The following is a description of a gene set: Genes down-regulated in Ly6C high monocytes: untreated versus rosiglitazone. species: Homo sapiens from publication Gautier EL, Chow A, Spanbroek R, Marcelin G, Greter M, Jakubzick C, Bogunovic M, Leboeuf M, van Rooijen N, Habenicht AJ, Merad M, Randolph GJ (PMID 22855714) Human Gene Set: GSE32034_UNTREATED_VS_ROSIGLIZATONE_TREATED_LY6C_HIGH_MONOCYTE_DN PPARγ is known for its anti-inflammatory actions in macrophages. However, which macrophage populations express PPARγ in vivo and how it regulates tissue homeostasis in the steady state and during inflammation is not completely understood. We show that lung and spleen macrophages constitutively expressed PPARγ, while other macrophage populations did not. Recruitment of monocytes to sites of inflammation was associated with induction of PPARγ as they differentiated to macrophages. Its absence in these macrophages led to failed resolution of inflammation, characterized by persistent, low-level recruitment of leukocytes. Conversely, PPARγ agonists supported an earlier cessation in leukocyte recruitment during resolution of acute inflammation and likewise suppressed monocyte recruitment to chronically inflamed atherosclerotic vessels. In the steady state, PPARγ deficiency in macrophages had no obvious impact in the spleen but profoundly altered cellular lipid homeostasis in lung macrophages. Reminiscent of pulmonary alveolar proteinosis, LysM-Cre x PPARγflox/flox mice displayed mild leukocytic inflammation in the steady-state lung and succumbed faster to mortality upon infection with S. pneumoniae. Surprisingly, this mortality was not due to overly exuberant inflammation, but instead to impaired bacterial clearance. Thus, in addition to its anti-inflammatory role in promoting resolution of inflammation, PPARγ sustains functionality in lung macrophages and thereby has a pivotal role in supporting pulmonary host defense., and this is the list of marker genes: MZT2B, C1QBP, CLCNKB, RAMAC, GPX7, FLCN, CFDP1, RBM3, SPR, GPAT4, RPS23, ST8SIA3, CAVIN2, CCR5, TAF8, NDUFC2, RBM8A, ZNF354A, MCM3AP, CA4, PRPSAP2, YPEL3, NDFIP1, APIP, MRPS12, BLTP3A, CASP9, ENTPD7, CCNI, SEM1, MDM2, TNKS2, RPL24, FCGRT, DPM3, SDHAF1, MRPS7, SEMA4F, KMT2E, BOLA2, AMH, NKIRAS1, ACKR3, TMEM179B, MAEA, ADRA2C, BCL2A1, RPS3A, LYRM2, APOE, RPF1, ERP44, BAG1, KLK4, HIGD2A, WASHC3, ZMYND8, CCDC186, BCAP31 (B cell receptor associated protein 31), CACYBP, MYO1F, QDPR, SMIM11, NMBR, TMEM223, UQCC5, NFIX, GON4L, PPA2, FBXL15, EEPD1, EID1 (NCBI Gene Id 27110), RSRP1, SLC6A12, MRPL11, CLK4, RPS6, P2RX4, MRPL49, USE1, CD99L2, LOXL1, LGR5, MCEE, ZMAT3, RPL6, CDV3, PDCD5, PPARG, CHCHD10, ETFB (electron transfer flavoprotein subunit beta), KIN, MRPL43, GRIA4, PSMG4, H2BC18, CHCHD7 (coiled-coil-helix-coiled-coil-helix domain containing 7), RPAP3, WDR55, FXYD2, CACUL1, MRPL41, TBCA, ZFP36L2, SERP1, CNR2, DNASE1L1, COPB1, CAPN7, CASP3, SARAF, TRIM27, PCK2, BEX1, FABP3, KLHL7, DPPA5 (NCBI Gene Id 359942), RPL13A, SLC25A39, SOCS3, ZKSCAN3, PHF7, AXL, KDM3A, MRPS26, KANK3, THBS1, NPM3, RHOB, TGIF1, HOXA13 (homeobox A13), ARL5A, KCNA2, RMND5A, FNDC7, FKBP9, SRP14, UGT8, SYNPO, RPS18, AURKAIP1, DBI, PSMD6, ABCC2, RPL14 (ribosomal protein L14), SUCLG1, TRAF1, PEBP1, PAXBP1, ZFP64 (ZFP64 zinc finger protein), TNIP1, RPL28, MAT2B, CLK1, RAB2A, EIF1B (NCBI Gene Id 10289), HMX1, GTF2I, CLEC16A, PSMC5, DIDO1, TARDBP (TAR DNA binding protein, NCBI Gene Id 81927), LSM4, PPARGC1A, GML, RTCB, IL1R2, SIN3B, VAMP3, P3H3, RASD1, TAF6, CYB5R4, OGT, CHKA, GNAS-AS1, RPL30, LAMTOR2, HSP90AB1, PNRC1, SEC61A2, LPIN1, ZNF821 (NCBI Gene Id 55565), TXNDC5, MSL1, EPB41L4A-AS1, SNX9, MLYCD, ARL4C (NCBI Gene Id 10123), DHRS7, ONECUT1, LYL1, KANSL2, MGP, KRT10, KGD4, MRPL27 (NCBI Gene Id 64988), RPS7 (ribosomal protein S7), SLIRP